The following is a description of a gene set: Any process that activates or increases the frequency, rate or extent of animal organ morphogenesis. Human Gene Set: GOBP_POSITIVE_REGULATION_OF_ANIMAL_ORGAN_MORPHOGENESIS species: Homo sapiens, and this is the list of marker genes: BMP4, WNT2, SOX8, MESP1, SOX9, HOXC11, MSX1, CTNNB1, SIX4, SIX1, FGF1 (NCBI Gene Id 29961), GATA5, FGFR1, TGFB1, HOXA11, EDN1, GDNF, CD34, POU5F1, GATA3, NGFR, FGF10, WNT4, BMP2, ROBO1, ROBO2, DKK1, FRS2, SPRY1, WNT2B, AR, FGF2, STOX1, FGF8, CSF1 (NCBI Gene Id 1435)